The following is a description of a gene set: The process whose specific outcome is the progression of the parathyroid gland over time, from its formation to the mature structure. The parathyroid gland is an organ specialised for secretion of parathyroid hormone. Mouse Gene Set: GOBP_PARATHYROID_GLAND_DEVELOPMENT species: Mus musculus, and this is the list of marker genes: Foxi3, Gcm2, Tbx1 (NCBI Gene Id 21380), Pax1, Gata3, Tgfbr1, Hoxa3, Crkl